Given this list of marker genes ERC2, RIMS2, CAST, ERC1, RIMS1, BSN, NRXN1, PCLO, RIMS3, RAB3A, PCDH17, here is a description of the gene set: studied in species Homo sapiens A process that results in the assembly, arrangement of constituent parts, or disassembly of a presynaptic active zone. Human Gene Set: GOBP_PRESYNAPTIC_ACTIVE_ZONE_ORGANIZATION